Given this list of marker genes DMAC2L, IDS, KRT2, TESK2, TMEM14C, UBE2B, SPICE1, TM9SF1, PLEKHS1, CLNS1A, SSR4, TAGLN, COG8, N4BP3, TFIP11, SPTBN1, DBH, DIO1, CDK1, CKAP2, PLPP2, MMP19, LAPTM4B, HMG20A, B2M, HCFC1, C19orf53, RPLP1, EEPD1, TLE5, HEXD, MAU2, CD300C, ABCB7, LUC7L3, ENTPD5, UBE2E1, ACOX2, C19orf12, SH3BGRL3, CD48, AP5M1, TMEM260, RASSF3, PALS2, LIMA1 (NCBI Gene Id 51474), NDUFAF7, RGL2 (NCBI Gene Id 9264), GRK5, CMTM6, DBR1, PNPLA7, LPGAT1, IL31RA, SELENBP1, GDA, OSBPL11, PLEKHA1, FAM98C, RPN2, HIP1, TPRN, TECPR1, NDUFS2, TTI1, NDUFS5, RAMP1, FAM162A, ASCC1, COMT, RBBP7, HABP4, LGALS8, NPY1R, SLC25A4, BCAS3, STXBP2, MAPRE3, CENPF, TKT, ZCCHC3 (zinc finger CCHC-type containing 3), RUFY3, HPCAL1, EHHADH, IRAG2, EML5, CCDC34, NDUFB2, CYRIB, MCEE, XPR1, IPO8 (NCBI Gene Id 10526), MYCBP2, ANP32B (acidic nuclear phosphoprotein 32 family member B), CLIC1, ZWILCH, GCNT1, CHCHD1, RNPC3, NSMCE4A, RNPEP, SMPD2, CROT, IFT122, RAD51, CAPN2, MBP, MFF, THOC7, GALNT2, CORO1A, TSPAN14, MPV17, KLF16, RPL6, CLYBL, MGAT2, EPSTI1, RBM43, AKR1B10, RNF181, EIF5A, MCM6, TRIM3, SERTAD1, TMPRSS4, SORCS2, FRG1, ATM, GPR87, MSL1, PTPN18, ITM2B, RFX1, SMIM14, TUBGCP3, MANBA, MCRIP1, NCOA1, LAP3, MRPL14, STARD4, SLC6A4, TIA1, NCAPH, ATP5F1A, CIB2, MIGA2, PRPSAP2, CIAO2A, ZNF688, MIDN, ANKRD10, RPL31, ENDOD1, ATG3, NME3, TPD52L2, DLGAP5, DCAF4, PAG1, PEPD, PTPN6, CDK2, CUL4B, NDUFC2, TRIM34, CXCR4, HASPIN, ARRB1, BDH1, ORC5, PLXDC1, IVD, MKNK1, MPP1, EIF4E3, DDIT4, RAP1A, SERINC3 (NCBI Gene Id 10955), KBTBD2, NCOR2, RNF167, SVIL, SOCS4, TOMM22, PRKAG1, PDXK, ALDH1L1, NQO2, MAP4K4, GNAS, NDUFAB1, TFB2M, SLF1, ACAT1, PPP1CC, PTPRO, OXR1, PCNA, here is a description of the gene set: Human Gene Set: GSE17721_CTRL_VS_PAM3CSK4_8H_BMDC_UP Genes up-regulated in comparison of control dendritic cells (DC) at 8 h versus those stimulated with Pam3Csk4 (TLR1/2 agonist) at 8 h. from publication Amit I, Garber M, Chevrier N, Leite AP, Donner Y, Eisenhaure T, Guttman M, Grenier JK, Li W, Zuk O, Schubert LA, Birditt B, Shay T, Goren A, Zhang X, Smith Z, Deering R, McDonald RC, Cabili M, Bernstein BE, Rinn JL, Meissner A, Root DE, Hacohen N, Regev A (PMID 19729616) species: Homo sapiens mouse primary BMDCs were stimulated with tlr ligands and gene expression changes were profiled on Affymetrix arrays